Given this list of marker genes CLCN3, TMEM67, TMEM216, KIAA0586, ARL3, LAMA1 (NCBI Gene Id 3907), AHI1, CSPP1, INPP5E, NPHP1, here is a description of the gene set: Human Gene Set: HP_ELONGATED_SUPERIOR_CEREBELLAR_PEDUNCLE species: Homo sapiens Increased length of the superior cerebellar peduncle. Elongated superior cerebellar peduncle